The following is a description of a gene set: Mouse Gene Set: REACTOME_MISMATCH_REPAIR_MMR_DIRECTED_BY_MSH2_MSH3_MUTSBETA Mismatch repair (MMR) directed by MSH2:MSH3 (MutSbeta) studied in species Mus musculus, and this is the list of marker genes: Msh2, Pold1, Pold4, Lig1, Rpa1 (replication protein A1), Pold2, Msh3, Rpa2, Pold3, Rpa3